Given this list of marker genes Trim13, Pcbp1, Fmr1, Furin, Itgav, Cd300ld, Jun, Zfp639, Ifih1, Smpd1, Slc20a2, Ifi206, Sp100, Trim21, Oas1g, Setdb1 (SET domain, bifurcated 1), Igf2r, Mx2, Adar, Srpk1, Oasl2, Isg15, Avpr1b, Cd209d, Chmp5, Oas3, Zfp809, Pdcd6ip, Atg12, Hdac1, Vps16, Tpcn1, Dhx9, Mbl2, Jpt2, Ddx3x, Cd209e, Spcs3, Trim8, Stau1, Zc3h12a, Ddx56, Top2b, Peg10, Eif2ak2, Chmp1a, Morc2a, Kpna2, Map3k1, Kpna6, Ppid, Nectin4, Itgb3, Mphosph8, Nectin2, Trim6 (NCBI Gene Id 94088), Ifnb1, Mndal, Ifnl3, Tbc1d20, Dynlt1f, AU040320, Smarcb1, Hcfc1, Prox1, Rab7, Taf11, Bst2, P4hb, Agtr1b, Nrp1 (neuropilin 1), Rnasel, Ptbp1, Chmp1b, Ltf, Clec4g, Adarb1, Nedd4, Ythdc2, Rrp1b, Slamf1, Larp7, Clec5a, Ifi209, Fkbp6, Tnf, Ccl3, Rsf1, Vps4a, Hsp90ab1, Denr, Apobec3, Mir24-1, Atg5, Ppia, Tsg101, Csf1r, Uvrag, Vcp, Zdhhc8, Cldn6, Mir378a, Atg16l2, Eps15, Ddb1 (damage specific DNA binding protein 1), Slc3a2, Usf1, Hyal2, Hmgb1, Lamp3, Zfyve1, Tardbp, Trim30b, Mcts1, Rest, Oas1f, Tmprss4, Arl8b, Stat1, Trim62, Pcbp2, Lgals1, Ccl8, Trim32, Mdfic, Hmga2, Srpk2, Tfap4, Ptx3, Mon1b, Trim25, Xpr1, Mavs, Cdk9, Gas6, Smc6, Mid2, Oaz1, Eif3l, Cxcr4 (NCBI Gene Id 12767), Lrrc15, Usp6nl, Ccnk, Eif3b (NCBI Gene Id 27979), Oas2, Ceacam1, Fam111a, Eif2ak4, Creb3, Ifi208 (interferon activated gene 208), Plscr1, Gm11772, Tmem41b, Rab1a, Pkn2, Tmprss11a, Smarca4, Nr5a2, Chmp2b, Banf1, Oas1a, Trim14, Ppih, Tpcn2, Oas1e, Oaz2, Ddx5, Tarbp2 (NCBI Gene Id 21357), Oas1h, Chmp1b2, Trim12c, Pikfyve, Aicda, Tmprss11d, Apcs, Chmp7, Gtf2b, Pou2f3, Oas1b (2'-5' oligoadenylate synthetase 1B), Nectin3, Mir93, Cd209c, Rsad2, Rnasek, Chd1, Stom, Ark2n, Larp7-ps (NCBI Gene Id 68280), Axl, Tmprss2, Trim30c, Zc3hav1, Ifitm3, Npc1, Chmp4c, Eif3d, Ifi213, Lrsam1, Trim15, Dynlt1b, Dicer1, Eif3a, Siglec1, Cav2, Cd74, Pde12, Ddx6, Cd300lf, Cldn9, Ifitm7, Hacd3, Bcl2, Trim12a, Trim28, Ppib, Hpn, Ppie, Oas1d, Insr, Hspa8 (NCBI Gene Id 69197), Spint1, Hexim1, Gpr15, Naip5, Ppihl, Ifitm2, Cd81, Trim11, Slc38a8, Trim30a, Ccl5, Mvb12b, Znfx1, Avp, Paip1, Vapa, Ubp1, Pcsk5, Ctdp1, Crebbp, Myh9, Ifi203-ps, Bicd1, Mvb12a (multivesicular body subunit 12A), Agtr1a, Chmp3, Phb1, N4bp1, Csde1, Chmp6, Eef1a1, Ifi203, Tmem39a, Lef1, Inpp5k, Ifng, Dynlt1c, Slpi, Tmprss11e, Dynlt1a, Tasor, Ilf3, Eif3g, Pfn1, Smc5, Ifi214, Gbp7, Oas1c, Icam1, Rab43, Eif3f, Tmem250, Chmp4b, Trim30d, Tyro3, Ccnt1, Larp1, Atg7, Ifitm6 (NCBI Gene Id 213002), Ch25h, Atg16l1, Cav1, Vapb, Dag1, Apoe, Ep300, Grk2, Zfp36, Nectin1, Ssb, Notch1, Pcx (NCBI Gene Id 18563), Ccnt2, Cfl1, Sp1, Trim38, Ace2, Ctsb, Rad23a, Fbxl2 (F-box and leucine-rich repeat protein 2), Prkn, Eif2d, Dpp4, Hs3st5 (heparan sulfate (glucosamine) 3-O-sulfotransferase 5), D1Pas1, Pik3c3, Snw1, Bsg, Oasl1, Trim5, Vps4b, Spcs1, Ifitm1, Top2a, Cd4, Vps18, Tnfrsf14, Siva1, Slc7a1, Trim27, Vps37b, Csnk2b, Chmp2a, Shfl, Zdhhc20, Cldn1, Zdhhc9, Rab1b (NCBI Gene Id 76308), Morc2b (NCBI Gene Id 240069), Trp53, Ist1, Mir24-2, Isg20, Brd4, Cnot7, Ifi207, Oaz3, Trim31, Vamp8, Nucks1, here is a description of the gene set: studied in species Mus musculus A multi-organism process in which a virus is a participant. The other participant is the host. Includes infection of a host cell, replication of the viral genome, and assembly of progeny virus particles. In some cases the viral genetic material may integrate into the host genome and only subsequently, under particular circumstances, 'complete' its life cycle. Mouse Gene Set: GOBP_VIRAL_PROCESS